The following is a description of a gene set: from publication Wood VH, O'Neil JD, Wei W, Stewart SE, Dawson CW, Young LS (PMID 17486072) Genes down-regulated in the Ad/AH cells (adenocarcinoma) engineered to stably express the Epstein-Barr virus (EBV) gene EBNA1. Human Gene Set: WOOD_EBV_EBNA1_TARGETS_DN species: Homo sapiens The Epstein-Barr virus (EBV)-encoded EBNA1 protein is expressed in all virus-associated tumors where it plays an essential role in the maintenance, replication and transcription of the EBV genome. Transcriptional profiling of EBNA1-expressing carcinoma cells demonstrated that EBNA1 also influences the expression of a range of cellular genes including those involved in translation, transcription and cell signaling. Of particular interest was the ability of EBNA1 to enhance expression of STAT1 and sensitize cells to interferon-induced STAT1 activation with resultant enhancement of major histocompatibility complex expression. A negative effect of EBNA1 on the expression of TGFbeta1-responsive betaig-h3 and PAI-genes was confirmed at the protein level in EBV-infected carcinoma cells. This effect resulted from the ability of EBNA1 to repress TGFbeta1-induced transcription via a reduction in the interaction of SMAD2 with SMAD4. More detailed analysis revealed that EBNA1 induces a lower steady-state level of SMAD2 protein as a consequence of increased protein turnover. These data show that EBNA1 can influence cellular gene transcription resulting in effects that may contribute to the development of EBV-associated tumors., and this is the list of marker genes: MFAP5 (microfibril associated protein 5), DYNLT3, ADAP2, S100A8, RAB13, IDI1, CALCOCO2, INSL4, KIF5B, TAX1BP1, MAP7, UGP2, TGFBI, SLC39A6, NUDT2, SLC27A5, MYLK, SGK1, GPNMB, CCN5 (NCBI Gene Id 8839), SLC16A7, IQGAP1, P2RY6, IPO7, C4BPB, PTGS2, TSPAN8, RGS2, MACF1, CLEC2B, EPB41L3, GOLGA4 (golgin A4, NCBI Gene Id 2803), ACAA2 (acetyl-CoA acyltransferase 2), SPOCK1, IL13RA1, SPHK1, KDELR2, TPM1, PSMB8, ALCAM, DPM3, ACTR2, GNAQ, S100P, ABCE1, ABCC4, AKAP12, MEST